The following is a description of a gene set: Human Gene Set: KEGG_MEDICUS_REFERENCE_EREG_EGFR_RAS_ERK_SIGNALING_PATHWAY EREG-EGFR-RAS-ERK signaling pathway. Pathway ID: N00277. Pathway type: Reference. Pathway class: nt06260 Colorectal cancer. studied in species Homo sapiens Pathway Definition from KEGG: EREG -> EGFR -> GRB2 -> SOS -> RAS -> RAF -> MEK -> ERK, and this is the list of marker genes: BRAF, EREG, MAPK1, RAF1, SOS1, MAPK3, KRAS, GRB2, SOS2, MAP2K2, EGFR (NCBI Gene Id 1956), ARAF, MAP2K1, NRAS, HRAS (NCBI Gene Id 338029)